Given this list of marker genes Fst, Numa1, Tgfb2, Foxn1, Wnt10b, Tnf, Wnt5a, Msx2, Gal, Krt17, Tradd, Hpse, here is a description of the gene set: Any process that activates or increases the frequency, rate or extent of hair follicle development. studied in species Mus musculus Mouse Gene Set: GOBP_POSITIVE_REGULATION_OF_HAIR_FOLLICLE_DEVELOPMENT